Given this list of marker genes ECE2, FCGBP, QDPR, KLHDC3, SORBS2, PRSS8, L1CAM, IFIT1 (interferon induced protein with tetratricopeptide repeats 1), GSTM5, ARG1, ATP6V0A1, GREM1, ARHGDIG, TRPM2, CCND1, DTX4, TFAP2B, RNASE3, APOB, SCAMP5, ODF1, FOS, FSTL3, MPPED1, TM4SF5, FEV, TNFRSF10B, SYNPO2L, SERPINA6, AGR2, PFKFB3, GFPT2, ADAM19, F10, CYP2J2, LTC4S, ELAC2, FN1, APOE, RBM38, LTF, HCN3, PIP, DLK1, PSG7, NRG2, EGR1, ETFB, PEPD, SEZ6L, S100A9, FGFR1, LGMN, IER3, SLC22A6, MSLN, MARF1, IFI27, SOX10, GCHFR, HYI, ASGR2, CDC42EP1, LCE2B, KCTD17, SERPIND1, PCLAF, DLC1, SGCE, LRCH4, TNFSF10, CHRNB1, PHLDA2, PRF1, ABCA1, CPB2, RAMP1, CDH16, MDK, KIF21B, FABP1, CFH, CADM1, TRPC4AP, DRD3, SELE, GNG7, PRG2, HSPA2, XPNPEP2, C8B, NR0B2, MT1G, RNF167, ACKR1, PLAT, IVL, GPA33, ITIH1, SBNO2, MAOB, REG1B, NAAA, N4BP2L1, CRIM1, IGFBP2, CDC20, PTTG1, CAV1, TYR, CYP2F1, ITGA5, RIMS2, CLDN4, DVL1, SST, HSD11B2, IGFBP4, IKBKG, ZBTB20, AMBP, UBE2L6, IL1RN, TACC2, ITGA10, FAM107A, HAAO, BBOX1, APOC1, TNXB (NCBI Gene Id 7148), C4BPB, ESR1, ITM2A, SRPX, CHGA, GNG12, CYP4F12, TIMP3, EPHX2, KRT14, SFRP1, TRIM15, CFB, QPCT, CD6, VGF, NFIL3, GOT1, ATOSB, HPD, SFTPC, MSMO1, RNASE2, CHST3, LDLR, TMSB4Y, P4HA1, GDF15, COL5A2, ECM1, PGC, ARL4A, PAEP, ECHS1, HBZ, GAGE12F, NCF1C (NCBI Gene Id 654817), SRRM2, PRELID3A, SLC22A1, KLK11, AQP1, GSTA2, TBR1, KCNQ1, GATM, PRSS2, ITGA7, FXYD2, KRT31, SOX9, AMELY, LSP1, CFAP410, C1S, FCN2, HLA-DMA, KRT4, PLA2G2A, MYOG, ADH1B, FURIN, HSD17B1, ASGR1, ETV3, CSF3R, CORO1A, CRYAA, MEF2C, INHBC, AANAT, DSP, HPGD, NNAT, NUPR1, FADS2, TPM2, COL4A1, CLDN8, SMAGP, ID2B, TM4SF4, FBP1, FETUB, TNFRSF1B, MST1, ITGA3, COL9A1, PTP4A3, ANK3 (ankyrin 3), PTPRCAP, ST6GALNAC4, RND1, GRM2, UMOD, CCL7, ACSL1, GPX3, CYP4B1, YPEL1, MME (membrane metalloendopeptidase), GCH1, CEACAM3, SLC37A4, LAMB2, CDK5R1, PLPP2, F2, PRR4, SLC38A10, TNNT3, APCS, KCNQ3, PCK1, KRT5, FST, CFD, TBX5, VEGFA, TNFRSF10C, HOXB1, PLAAT3, NECAB3, SMARCD3, SRPK3, ACR, HRG, GAS8, CYP4A11 (cytochrome P450 family 4 subfamily A member 11), H4C3, MYL9, FAT2, C4BPA, PSD, ETS2, STOML1, PTPRN2, VWF, SERPINC1, TBXT, ACTN1, SLC22A18AS, TCL1A, IGF1, SEMA6C, ZBED4, STAB1, RAB31, CES1, RBP4, AK4, AMY2B, CEP135, CYP2E1 (cytochrome P450 family 2 subfamily E member 1), SELENOP, UBL3, TFR2, PROC, FBN2, IL7R, DEPP1, HNF1B, ST6GAL1 (NCBI Gene Id 6480), FLT1, BRD4, TBCD, CRLF1, SERPINA1, DPP4, HSPG2, SORD, SLC2A3, TULP1, CREB3L1, SPINK1, FMO4, DEFA3, AQP7, AMT, CCND2, SLC4A4, IL1R1, SPP1, COX7A1, TBX1, KNG1, UGT2B7, CDH1, CDR2L, APOL1, CYP2B6, GPC3, ITGB5, ECI1, PAX4, PGAM2, LECT2, NRGN, GPR3, COL6A1, SLC43A1, TSPAN8, IQGAP2, CEL, CDK18, TNFRSF6B, TACSTD2, GNMT, PDE2A, FCGRT, CCNF, CST7, IGFBP1 (NCBI Gene Id 3484), IGHG3 (NCBI Gene Id 3502), PIGO, CYB5A, SNCG, RBMXL2, KCNN4, EDA, ADM, EFS, TCF7, ENPP1, NAT8, WDR7, PLK3, ATP9A, MUC5B, ADIRF, CTSC, PTPRN, CD37, WWC1, PPL, EPHX1, ITIH4, SLCO2B1, ABCC3, LPL, DNAJB2, ABLIM1, UCN, G0S2, PIM2, DNASE1L3, CELA2B, ARFIP2, HLA-DQB1, AMELX, TGM4, GRN, SCNN1A, LMO2, CPS1, HMGCS2, ALPL, CCL2, APOC4, C7, SERPINA4, ADH1C, DEFB1, TRIB1, STX1A, PHLDA1 (NCBI Gene Id 22822), DHRS3, EFNA2, CCL15, UBE2C, CYP2A7, LIF, CD33, ECM2, GATA1, WFDC2, ALDH3A2, ACP5, ADRA2C, SDC1, NTNG1, ALDH7A1, SLC17A7, COL7A1, CLEC3B, DAO, CRYM, F12, AAK1, FADS1, HOMER2, GMPR, AOC1, TNFRSF14, NR2E3, GTSE1, NQO1, GALR3, MFAP2, RAC3, ATP11A, DPYSL4, CRABP1, TLE2, LBP, DDIT4, DLEC1, HSPA6, C5, APOC2, FGFR2, IGFBP3, DNM2, MAOA, EMP3, CFP, COL18A1, CLDN9, TRAPPC6A, PLCB2, HMOX2, CD79A, H3C6, ALDH1L1, MGLL, HTR4, FXYD1, LY6D, KRT7, C1QB, PLAU, MAGI1, NME3, S100A4 (NCBI Gene Id 6275), SLC10A1, CDKN1A, SHBG, CRYAB, ENG, KIAA0586, ACSL6, SERPINF2, HOXB2, SLC29A2, C8A, IHH, SLC6A11, GYPB, SLC7A7, EPOR, NEBL, GRIK5, TM7SF2, ABLIM3, UGT2B15, PRB4, RARRES2, DUSP6, HMOX1, C2, SCNN1B, ITIH2, LRRC32, SERPINE1, APOA4, MYRF, DDC, EXD2, PTH1R, LPCAT1, CHI3L2, FGL1, ALDH1A1, TFAP2A, CRYZ, HPN, PDE4C, ALDOB, EPB41L3 (erythrocyte membrane protein band 4.1 like 3), NFKBIB (NFKB inhibitor beta), ZKSCAN3, SV2A, CBS, HSD11B1, PTN, FMO3, HP, PLEC, FMO5, AMACR, GRK1, LY6G6C, RAC2, SLC17A3, ATP2A3, PAX6 (paired box 6), KRT86, ADH1A, PALM, THRA, SCG5, OCLN, LYPD3, ELN, REN, SNAP25, ZIC2, MPO, SERPINA5, NRTN, CYP27A1, MSMB, MMP2, CYB5R1, FBLN2, DPH2, VSIG4, GPT, ATP4A, FGA, IGSF1, GLYAT, KCND3, PPP4R2, AADAC (arylacetamide deacetylase), CCN1, LRP3, DRD2, STK39, PEG10, PPBP, DHRS2, FKBP1B, TSPAN1, MYH2, GAS1, ALDH1A3, ABAT, BLVRB, BDH1, COL6A3, EIF4EBP1, BMP10, KRT18, PHYHIP, DHRS1, GLRB, CNKSR1, PDZK1IP1, PTPRO, TSPAN7, AKR1C1, ITGA6, AKR7A3, BSN, SMTN, LTBR, ZYX, APBB1, ARFGAP3, VTN, RGS10, CCL21, LAPTM5, CLDN7, CCR1, AR, S100A8, FGFR4, ALB (albumin), NECTIN2, ATF5, PCBD1, IL2RG, APLP1, BCAM, TGFBI, CCKAR, IGFBP6, MTHFR, CA12, GSTM1, AEBP1, SRGN, CLDN10, SDS, PNRC1, CST1, MAL, HBD, CHRNB4, AQP9, PHYH, PAH, SCP2, FOLR1, CPN2, RGN, DNASE1, ENPEP, COL1A2, SLC6A2, FAT1, IVD (NCBI Gene Id 3712), LAIR1, NNMT, IL4R, FOXO4, PLIN2, MYLK, CDH4, C6, TGM2, GALNS, TRIM29, TCN2 (NCBI Gene Id 6948), PLG, CD151, LGR5, AQP3, GPR17, SOD3, HAP1, ASIP, ENTPD2, INSIG1 (insulin induced gene 1), FBXL7, TFF3, RCVRN, CFHR1, AGXT, LGALS4, EPCAM, UBXN1, ALDH1B1, GLRX, FGFR3, SYNGR4, HSPBP1, XDH, DBP, H2BC21, RIBC2, SLC16A4, CYP2C8, STARD5 (StAR related lipid transfer domain containing 5), APOD, PDGFRA, PRSS16, HPR, SLC1A6, CPE, RNASE4, MYH11, HGD, RHOD, CASP2, SLC7A8, BMP1, NGFR, HYAL1, ISG15, CLCNKA, TM4SF1, IL32, JAK3, PROM1, CYP3A7, SIX6 (NCBI Gene Id 4990), TBC1D2B, TRIM16, ANPEP, RNASE1, UGDH, JUNB, ORM2, SERPINA3, FZR1, CYP2C19, ELAVL2, CCN5, SPP2, ABCA3, KCNMB1, RBMS3, CKS2, APOH, ITGA2B, EPHA2, NFKBIL1, FCER1G, DTNB, CCHCR1, AGT, ITIH3 (inter-alpha-trypsin inhibitor heavy chain 3), CTSG, HSD17B6, CITED2, AQP5, PAX7, IGF2, TMEM97, LST1, PSD4, LDOC1, RRP9, PFKFB2, RHBDL1, RECQL5, AQP8, DNAH3, CD14, CLDN3, UNC13B, AKR1C3, FGB, SLC4A1, SLC7A11, COL6A2 (NCBI Gene Id 1292), TDO2, ACOX2, AZGP1, ALAS2, RHOB, RAMP2, CD163 (NCBI Gene Id 9332), GPX2, CP, DDT, NR4A1, MUC1, EFNA1, NHERF1, PEG3, KRT19, PER1, ALAS1, XK, LEFTY1, GPRC5B, PTGIS, APOA1, NCALD, CFI, ENPP2, GC, EPAS1, ALDH4A1, KCNA5, BARX2, H2BC12, DMBT1, LRIT1, S100A11, GPSM3, NEURL1, PCOLCE, PLEKHO2, SHMT1, S1PR4, GATA2, PNOC, WNT10B, CA2, COL2A1, IGHM, GADD45G, AHSG, SMOX, TIMM17B, GPNMB, ERBB3, CA4, CAV2, GSTT1, RBP1, BCKDK, SCO2, GJB1, APOM, DIO1, COL1A1, GCG, PON3, TNFRSF13B, MAT1A, PCK2, COL3A1, SLC7A4, REG1A, PRSS3, LCAT, EGFR, CLDN5, HBEGF, ABCC6, APEX2, SSTR2, LCN2, FPR2 (NCBI Gene Id 2358), DKK4, PLCH2 (phospholipase C eta 2), CD24, GNE, SLPI, here is a description of the gene set: Heart, liver, kidney and pancreas metabolic and xenobiotic response genes. Human Gene Set: MODULE_88 species: Homo sapiens